The following is a description of a gene set: Any process that activates or increases the frequency, rate or extent of hematopoietic progenitor cell differentiation. Mouse Gene Set: GOBP_POSITIVE_REGULATION_OF_HEMATOPOIETIC_PROGENITOR_CELL_DIFFERENTIATION species: Mus musculus, and this is the list of marker genes: Il3, Zbtb1, Znhit1, Dhx36, Kitl, Hmgb1, Flt1 (FMS-like tyrosine kinase 1), Nudt21, Foxc1